Given this list of marker genes Rnls, App, Prkd1, Gk, Aplp1, Nr1h4, here is a description of the gene set: Mouse Gene Set: GOBP_RESPONSE_TO_NOREPINEPHRINE Any process that results in a change in state or activity of a cell or an organism (in terms of movement, secretion, enzyme production, gene expression, etc.) as a result of a norepinephrine stimulus. Norepinephrine is a catecholamine that has the formula C8H11NO3; it acts as a hormone, and as a neurotransmitter in most of the sympathetic nervous system. species: Mus musculus